The following is a description of a gene set: species: Homo sapiens Human Gene Set: MIR651_5P from publication Chen Y, Wang X (PMID 31504780) Genes predicted to be targets of miRBase v22 microRNA hsa-miR-651-5p in miRDB v6.0 with MirTarget v4 prediction scores > 80 (high confidence targets)., and this is the list of marker genes: USF3, FMN1, RORA, CSE1L, SPRR3, PROX1, MYO1E, UBE2H, BCOR, RPS23, BMPR2, LRP6, KCNV1, CD8B, USP33, TPTE, ACMSD, RAP1B, CETN3, AGK, GATM, GHR (NCBI Gene Id 2690), SMARCA1, STXBP1, ATG3, ERCC8, GTF2H3, ELAC1, MEIOC, CDK12, RGPD2, BMP2K, LPP, KIAA1671, SIX5, SORCS1, KICS2, ATP5MF, TNFRSF11A, CALM1, C6orf47, WBP11, HSPH1, PKHD1, MLLT3, C3orf70, DCTD, HBS1L, CADM2, FKTN, PRKAA2, CATSPERB, SNX20, SEC11C, STRADB, RGPD1, FUT9, PNPLA4, CAPS2, CBX5, OGFRL1, MAP3K2, UEVLD, CNTNAP2, SPDYE5, NT5DC1, BHLHE40, SEC62, NIPAL1, SPDYE1, PDE4D, DACH1, TOX3, FKBP5 (FKBP prolyl isomerase 5), GMFB, ZNF84, DEFA4, CNKSR2, MOSPD2, PRDM5, PTPN21, SIVA1, DTD1 (D-aminoacyl-tRNA deacylase 1), SLC4A4, GALNT1, SLITRK1, ZMYM6, SFMBT1, SEC23B (NCBI Gene Id 980), ENOSF1, SART3, MEMO1, REST, DEPDC7, CTSS (NCBI Gene Id 50653), SEC11A, CHD6, GFRA1, ATP1B4, SPDYE6, PLCXD3, NAT2, BIRC3, MAD2L1BP, CAVIN4, ZBTB20 (zinc finger and BTB domain containing 20), TNFRSF10B, KCNC2, KLLN, CFL2, TM9SF3, CDCP1, ACBD3, SLC1A2, PUM1, SPDYE3, MPHOSPH8, C1orf53, UBE2W, CFAP418, SVIP